The following is a description of a gene set: species: Homo sapiens TP53 Regulates Transcription of Death Receptors and Ligands Human Gene Set: REACTOME_TP53_REGULATES_TRANSCRIPTION_OF_DEATH_RECEPTORS_AND_LIGANDS, and this is the list of marker genes: TP73, IGFBP3, TMEM219, FAS, TNFRSF10A, TP63, TNFRSF10D, TNFRSF10C, TNFRSF10B, PPP1R13B, TP53BP2, TP53 (tumor protein p53)